Given this list of marker genes SORD, XYLB, DCXR (dicarbonyl and L-xylulose reductase), AKR1A1, CRYL1, here is a description of the gene set: Reactome Pathway: Formation of xylulose-5-phosphate part of: Metabolism of carbohydrates and carbohydrate derivatives studied in species Homo sapiens The conversion of D-glucuronate to D-xylulose-5-phosphate, an intermediate in the pentose phosphate pathway, proceeds via L-gulonate, 3-dehydro-L-gulonate, L-xylulose, xylitol, and D-xylulose. D-glucuronate can be generated via the degradation of glucuronidated proteins. This pathway would have the effect of returning it to the pentose phosphate pathway or glycolysis.